The following is a description of a gene set: Neurotransmitter receptors and postsynaptic signal transmission Mouse Gene Set: REACTOME_NEUROTRANSMITTER_RECEPTORS_AND_POSTSYNAPTIC_SIGNAL_TRANSMISSION studied in species Mus musculus, and this is the list of marker genes: Dlg2, Adcy5, Gabra6, Cacng3, Prkar1a, Pick1, Ncald, Adcy2, Chrng (NCBI Gene Id 11449), Cacng4 (calcium channel, voltage-dependent, gamma subunit 4), Glra2, Gng3, Glra3, Gabrg2, Chrnd, Adcy3, Kcnj16, Glra1, Dlg4, Grik4 (NCBI Gene Id 244825), Gabrq, Prkar1b, Grik1, Gng8, Gngt1, Adcy9, Grik5, Gabrr1, Gabra3 (NCBI Gene Id 14396), Rps6ka6, Gng4, Gria4, Ap2m1, Gria3, Chrna2, Tspan7, Adcy1, Nefl, Chrna3, Grin2d, Ap2a1, Kcnj2, Calm1, Gabrr2, Grin1, Chrnb2, Chrna4, Camk1, Rps6ka3, Kcnj15, Gabra1, Mdm2, Chrna7, Cacng8, Ap2a2, Camk2d, Camkk1, Gnb5, Gnat3, Rps6ka1, Gng12, Adcy6, Gnai2, Cacng2, Grin2a, Chrnb4, Kcnj12, Chrna1, Chrna6, Adcy8, Gria2, Arhgef9, Gabra5, Plcb3, Grip2, Gabrg3 (NCBI Gene Id 70716), Prkcg, Htr3a, Grip1, Gnb4, Rps6ka2, Gng10, Chrna5, Chrnb3 (cholinergic receptor, nicotinic, beta polypeptide 3), Kcnj4, Gnb3, Plcb1, Gng11, Dlg1, Gng5, Htr3b, Gngt2, Grin2c, Gnb2, Lrrc7, Akap5, Gnai1, Plcb2, Creb1, Grin3a, Calm3, Ap2b1, Adcy7, Ap2s1, Grik3, Calm2, Adcy4, Gabra2, Gabrr3, Chrne, Prkacb, Chrna9, Grik2, Myo6, Camk2g, Gria1, Gabrb3, Gng2, Gng13, Nsf, Gnal, Gabrb1, Kcnj6, Kcnj3, Camkk2, Prkaca, Actn2, Gnai3, Camk2b, Gabra4, Gabrb2, Gng7, Kcnj9, Camk2a, Glrb, Gnb1, Gabbr1, Prkcb, Kcnj10, Dlg3, Gabbr2, Kcnj5